The following is a description of a gene set: studied in species Mus musculus Mouse Gene Set: REACTOME_HUR_ELAVL1_BINDS_AND_STABILIZES_MRNA HuR (ELAVL1) binds and stabilizes mRNA, and this is the list of marker genes: Nup214, Elavl1, Set, Tnfsf13, Xpo1, Prkcd, Anp32a